Given this list of marker genes APOA2, FURIN, APOE, CREB3L3, APOC3, APOF, LMF1, LPA, MTTP, ANGPTL8 (angiopoietin like 8), CIDEC, PCSK6, PCSK5, GPIHBP1, MBTPS1, APOA1, ANGPTL3, PLTP (phospholipid transfer protein), APOC2, MBTPS2, APOA4, ALB, APOA5 (apolipoprotein A5), LMF2, ANGPTL4, LPL, FGF21, P4HB, LCAT, APOB, ABCG1, LIPG, CETP, LIPC, here is a description of the gene set: Reactome Pathway: Plasma lipoprotein remodeling As chylomicrons circulate in the body, they acquire molecules of apolipoproteins C and E, and through interaction with endothelial lipases can lose a large fraction of their triacylglycerol. These changes convert them to chylomicron remnants which bind to LDL receptors, primarily on the surfaces of liver cells, clearing them from the circulation. This whole sequence of events is rapid: the normal lifespan of a chylomicron is 30 - 60 minutes.<br>As they circulate, VLDL are acted on by lipoprotein lipases on the endothelial surfaces of blood vessels, liberating fatty acids and glycerol to be taken up by tissues and converting the VLDL first to intermediate density lipoproteins (IDL) and then to low density lipoproteins (LDL).<br>HDL remodeling includes the conversion of HDL-associated cholesterol to cholesterol esters (remodeling of spherical HDL), the transfer of HDL lipids to target cells with the regeneration of pre-beta HDL (lipid-poor apoA-I), and the conversion of pre-beta HDL to discoidal HDL. part of: Plasma lipoprotein assembly, remodeling, and clearance species: Homo sapiens